The following is a description of a gene set: Signaling by NOTCH3 Mouse Gene Set: REACTOME_SIGNALING_BY_NOTCH3 studied in species Mus musculus, and this is the list of marker genes: Uba52, Notch3, Ncstn, Egfr, Uba52rt, Aph1b, Ybx1 (NCBI Gene Id 97156), Aph1a, Adam10, Dll1, Jag2, Ubc, Psenen, Ubb, Dll4, Psen1, Jag1, Egf, Wwp2, Rps27a